Given this list of marker genes Shh, Foxf1, Igf1 (NCBI Gene Id 320499), Sec24b, Tgfbr2, Lif, Grhl2, Gata4, Fgfr2, here is a description of the gene set: Mouse Gene Set: GOBP_LUNG_LOBE_DEVELOPMENT species: Mus musculus The biological process whose specific outcome is the progression of a lung lobe from an initial condition to its mature state. This process begins with the formation of a lung lobe by branching morphogenesis and ends with the mature structure. A lung lobe is one of the rounded projections that compose the lung.